Given this list of marker genes RELA, PANX1, NLRC4, TXNIP (NCBI Gene Id 10628), BCL2, HMOX1, SUGT1, PYCARD, CASP1, NLRP1, TXN, NFKB1, NLRP3 (NCBI Gene Id 9558), AIM2, NFKB2, PSTPIP1, APP, P2RX7, MEFV, BCL2L1, HSP90AB1, here is a description of the gene set: Inflammasomes Human Gene Set: REACTOME_INFLAMMASOMES studied in species Homo sapiens